Given this list of marker genes INHBA, RAB8B, NFKBIZ, TFRC, SCG5, GLYR1, SKP2 (S-phase kinase associated protein 2), APH1A, ITGA6, PXN, ODAPH, EXOC5, TNFRSF10B (TNF receptor superfamily member 10b), DUS3L, BCL2A1, ASPH, MYCT1, CSF2, DHX9, SCYL2, SF3B5, ADAMTS6, PCGF5, SAA1, COPA, CDV3, LARP4, HMGA2, HSF1 (NCBI Gene Id 642255), DPY19L1, SNAP23, TPR, DOCK4, LPXN, IL1A, NCEH1, ATP13A3, KISS1, PPP2R1B, NAB1, PAX8-AS1, IQGAP1, SLC39A14, PLEC, RPL27A, PLAU, CSTF2T, PTBP1, OSMR, TGFBR2, DDX42, MEGF10, SPRED2, HMGA1, RBPMS2, MLX, SUPT16H, SNHG16, GNA13, CDC42SE2, RDUR, TCN1, UEVLD, MYH16, ITPRID2, ZC3H12A, USP16, CREBL2, SUPT6H, SLC6A15, GFPT2, CCND2, CDC27, C4orf46, TNFRSF11B, TIMM17A, TWF1, TGM2, AADAC, STYX, TNFAIP3, IL7R, PDLIM4, SH3PXD2A-AS1, CCNJ, CTDSPL2, SLC16A1, RAB5A, TGFB2, PLK4, PTPN12, ELK3, RBM14, BCLAF1, CBFB, MTAP, G0S2, DNAJB14, NAMPT, AGO2, CXCL8, TAF3, IL6ST, KMT5AP1, LMAN1, HACD2, KYNU, MCM4, MMP9, FBXO32, MCL1, CA2, RAB5C, SKIC3, PSME4, ANTXR2, here is a description of the gene set: Human Gene Set: SENESE_HDAC2_TARGETS_UP from publication Senese S, Zaragoza K, Minardi S, Muradore I, Ronzoni S, Passafaro A, Bernard L, Draetta GF, Alcalay M, Seiser C, Chiocca S (PMID 17470557) Genes up-regulated in U2OS cells (osteosarcoma) upon knockdown of HDAC2 by RNAi. Posttranslational modifications of core histones are central to the regulation of gene expression. Histone deacetylases (HDACs) repress transcription by deacetylating histones, and class I HDACs have a crucial role in mouse, Xenopus laevis, zebra fish, and Caenorhabditis elegans development. The role of individual class I HDACs in tumor cell proliferation was investigated using RNA interference-mediated protein knockdown. We show here that in the absence of HDAC1 cells can arrest either at the G(1) phase of the cell cycle or at the G(2)/M transition, resulting in the loss of mitotic cells, cell growth inhibition, and an increase in the percentage of apoptotic cells. On the contrary, HDAC2 knockdown showed no effect on cell proliferation unless we concurrently knocked down HDAC1. Using gene expression profiling analysis, we found that inactivation of HDAC1 affected the transcription of specific target genes involved in proliferation and apoptosis. Furthermore, HDAC2 downregulation did not cause significant changes compared to control cells, while inactivation of HDAC1, HDAC1 plus HDAC2, or HDAC3 resulted in more distinct clusters. Loss of these HDACs might impair cell cycle progression by affecting not only the transcription of specific target genes but also other biological processes. Our data support the idea that a drug targeting specific HDACs could be highly beneficial in the treatment of cancer. studied in species Homo sapiens